The following is a description of a gene set: Human Gene Set: GOBP_RESOLUTION_OF_DNA_RECOMBINATION_INTERMEDIATES studied in species Homo sapiens The cleavage and rejoining of intermediates, such as Holliday junctions, formed during DNA recombination to produce two intact molecules in which genetic material has been exchanged., and this is the list of marker genes: EME2, MUS81, RMI2, GEN1, XRCC3, TOP3A, BLM, EME1, RMI1